Given this list of marker genes FGFR4, FGF6, FGF23, FGF19, FGF16, KLB, FGF1, FGF18, FGF9, FGF17, FGF20, FGF4, FGF2, FGF8, here is a description of the gene set: studied in species Homo sapiens part of: Signaling by FGFR4 Reactome Pathway: FGFR4 ligand binding and activation FGFR4 is expressed mainly in mature skeletal muscle, and disruption of FGFR4 signaling interrupts limb muscle formation in vertebrates.